The following is a description of a gene set: Enables the transmembrane transfer of a solute by a channel that opens in response to a specific stimulus. studied in species Mus musculus Mouse Gene Set: GOMF_GATED_CHANNEL_ACTIVITY, and this is the list of marker genes: Kcnd3, Trpm4, Cacnb1, Clcnkb (chloride channel, voltage-sensitive Kb), Kcnk6, Chrna10, Atp5mc3, Itpr3, Clca3b, Glra3, Kcna4, Kcnab2, Chrna9, Calhm3, P2rx4, Trpm8 (NCBI Gene Id 171382), Gabre, Kcnt1, Grik5, Cacna1d, Lrrc55, Chrne (NCBI Gene Id 11448), Kcnb2, Kcnk1, Kcnmb3, Kcna1, Scnn1g, Tmc4 (transmembrane channel-like gene family 4), Kcnab1, Snap25, Clca1, Kcne5, Kcnj10, Clca3a2, Kcnh3, Kcnc2, Cacng5, Tmem37, Trpv1, Cav1, Trpv4, Grik1 (glutamate receptor, ionotropic, kainate 1), Kcnab3, Clcn2 (NCBI Gene Id 404589), Kcnj9, Mcoln3, Calhm6, Kcnn4, Vdac1, Chrna7, Nmur2, Ano4, Grid1, Catsper2, Kcnt2, Grin3b, Itgav, Chrna4, Cnga3, Gria3, Kcna10, Kcnj5, Kcnn1, Grm7, Ryr3, Glra1, Ryr2, Pkd1l3, Kcnq2, Kcnj4, Tmc3, Cacna2d1, Cacna1g, P2rx3, P2rx5, Kcnk18, Kcnq3, Asic4, Gabrb3, Grik4, Kcne2, Kcnj2, Gabra6, Cngb3, Kcnd2, Clcn3, Gabrq, Slc1a5, Kcne1, Tmc1, Ano6, Kcnb1, Ano10, Grin2a, Tmc7, Kcnn2, Kcng4, Chrng, Grin2b, Kcna5, Kcnmb4, Tmem63a, Kcnip2, Mcoln2, Calhm1, Kcnk3, Catsper4, Vdac3, Hcn4, Tpcn2, Htr3a, Trpa1, Glrb, Gabra4, Kcnh4, Grid2, Kcnq4, Kcnk12, Ano5, Kcns1, Tmc5, Aqp1, Cacna2d4, Kcne4, Tmem38a (NCBI Gene Id 74166), Grik3, Glra2, Kcnq1, Mcoln1, Catsper3, Gria2, Chrnd, Kcng1, Kcnh5, Gabrb2, Kcnk16, Gabra2, Trpm5, Slc17a3, Kcnma1, Cnga1, Cacna1a, Ano7, Kcnj6, Ano9, Scn10a, Gabrp, Scn7a, Rimbp2, Cngb1, Kcnv1, Gabrg2, Grin1, Cnga4, Chrna6, Kcnh8, Anxa6, Cftr (cystic fibrosis transmembrane conductance regulator), Cacnb4 (calcium channel, voltage-dependent, beta 4 subunit), Kcnq5, Pkd2l1, Asic1, Lrg1, Asic3, Chrna1, Cacna1b, Clca4b, Kcnj11, Gria1, Kcnj12, Tmc2, Tpcn1, Scn2b, Grik2, Gabrg3, Piezo1, Kcnh1, P2rx1, Kcna7, Rasa3, P2rx2, Cachd1, Best3, Cacna1c, Clca3a1, Catsper1, Hcn3, Ncs1, Atp5mc1, Chrna3, Kcnj1, Ryr1, Clcn5, Vdac2, Htr1b, Clcn1, Cacng3, Gabrr1 (NCBI Gene Id 14408), Cacng4, Kcnh6, Tmc6, Kcnv2, Chrm5, Best2, Pex5l, Lrrc26, Cacng7, Gpr89, Grin2c, Tmem109, Gabrg1, Gabrd, Nalf2, Kcnd1, Kcnc4, Aqp6, P2rx6, Grin3a, Scnn1b, Cacna1e, Pkd2, Cacna1f, Kcnj16, Kcns2, Chrna5, Kcnc1, Gabrb1, Hcn2, Trpm2, Lrrc38, Ttyh1, Nalf1, Ttyh3 (tweety family member 3), Chrnb3, Kcnmb1, Clcn4, Cacna2d2, Kcnj15, Ano2, Clca4a, Kcnh2, Kcna3, Scn1a, Chrnb4, Ano1, Ccdc51, Kcnk2, Gabra3, Kcnk9, Kcnh7, Hvcn1, Best1, Kcnk10, Asic2, Tmem63c, Scnn1a, P2rx7, Kcnu1, Cacng8, Kcna6, Tspoap1, Cacna1h, Cacng1, Cacnb3, Piezo2, Itpr1, Clca2, Kcnj3, Kcnk13, Htr3b, Asic5, Chrnb2, Cnga2, Cacng2, Grin2d, Hcn1, Scn2a, Chrnb1, Kcnk7, Gabra5, Slc1a7, Kcnc3, Ano3, Kcnf1, Slc17a7, Kcng3, Atp5mc2, Clcnka, Kcnj14, Kcns3, Cacna2d3, Chrna2, Tmc8, Itpr2, Oprm1, Gabrr2, Ttyh2, Cybb, Trpc3, Tmem63b, Kcnk5, Ano8, Tmem150c, Gabra1, Kcnk4, Gria4, Clcn6, Kcne3, Cacna1i, Pacc1, Kcnmb2, Cacnb2, Kcnn3, Kcna2, Tmem266, Cacna1s, Bnip1, Lrrc52, Kcnj8, Kcnj13, Glra4 (glycine receptor, alpha 4 subunit)